The following is a description of a gene set: studied in species Mus musculus Mouse Gene Set: MIR_200B_5P Genes predicted to be targets of miRBase v22 microRNA mmu_miR_200b_5p in miRDB v6.0 with MirTarget v4 prediction scores > 80 (high confidence targets). from publication Chen Y, Wang X (PMID 31504780), and this is the list of marker genes: Sp3, Mfap3l, Crlf3, Ranbp3, Impa1, Usp53, Kcns3, Arx, Faxc, Ube3a, Rufy2, Insig2, Ubr3, Usp22, Hmgcs1, Zbtb11, Btbd1, Bclaf3, Dlk2, Ccdc102a, Chml (choroideremia-like), Tfpi2, Tmem39a (NCBI Gene Id 67846), Kmt2e, Srsf6, Lmtk2, Atad2, Dzip3, Chd7 (NCBI Gene Id 57137), 4930447C04Rik, Foxc1, Msr1, Atp6v1a, Gls, Pgap4, Rab1a, Fsd1l, Invs, Jchain, Actr6, Hapln1, A1bg, Npy2r, Cyp2c50, Shprh, Atp6v0a2, Papolg, Klf6, Syt6, Sox21, Brpf3, Nr4a1, Htr2c, Fgf13, Nampt (nicotinamide phosphoribosyltransferase), Smchd1, Nsg2, Ascc3, Nxf1 (nuclear RNA export factor 1), Ssbp2, Ripply3, Spag6l, Irak2, Rasgrp1, Kif3c, Wnt5a, Nlgn1, Armc1, Zic4, Plpp3, Dhx8, Tmprss11e, C1d, Evx2, Zfp715